Given this list of marker genes H2-Q6, Eif5, N4bp2l2, Fosb, Icosl, Pnkd, Ciao2a, Fchsd2, Ccl22, Bmt2, Rassf4, Slc4a8, Tpm1, Creg1, Cd44, Gramd1b, Colgalt1, Hspa1b, Slc44a1, Klf7 (NCBI Gene Id 93691), Tcf3, Sik2, Slc25a29, Pkd1, Mob3a, Tspan3, Uqcr10, Swap70, Atp2b1 (ATPase, Ca++ transporting, plasma membrane 1), Znrf2, Zc3h12c, Arhgap22, Mknk2, Rab32, Sox4, Hspa1a, Kctd12, Pbxip1, Ankrd35, Mrpl33, Tspan33, H1f2, Tuba1c, Mylip, Nrp2, Topbp1, Tcf7l2, Septin9, Mt2, Gpx1 (NCBI Gene Id 14775), Tmem158, Anxa3, Gpx4 (glutathione peroxidase 4), Ppp4r2, Ebi3, Wdr91, Pnisr, Ankrd33b (ankyrin repeat domain 33B), Huwe1 (NCBI Gene Id 97602), Rgs3, Clu, Calr, Rubcn, Mt1, Slco5a1, Synpo2, Dennd4a, Jun, Arhgap31, Srrm2, Ttc14, Ftl1, Tnfrsf1b, Insr, Mark3, Nabp1, Sec11c, Ucp2, Sema4a, Vhl, Tnfaip2, Chka, Kcnq1ot1, Sdhaf1, Tnrc6b, Plxnd1, Dusp1, Sema6d, Malt1, Glipr1, Prex1, Zfp445, Lmo4, here is a description of the gene set: Genes negatively differentially expressed in cell type: MigDC (migratory dendritic cell) upon treatment with cytokine: IFN-α1 in mouse lymph nodes in vivo. Cytokines mediate cell-cell communication in the immune system and represent important therapeutic targets. A myriad of studies have highlighted their central role in immune function, yet we lack a global view of the cellular responses of each immune cell type to each cytokine. To address this gap, the authors created the Immune Dictionary, a compendium of single-cell transcriptomic profiles of more than 17 immune cell types in response to each of 86 cytokines (>1,400 cytokine-cell type combinations) in mouse lymph nodes in vivo. A cytokine-centric view of the dictionary revealed that most cytokines induce highly cell-type-specific responses. For example, the inflammatory cytokine interleukin-1β induces distinct gene programmes in almost every cell type. A cell-type-centric view of the dictionary identified more than 66 cytokine-driven cellular polarization states across immune cell types, including previously uncharacterized states such as an interleukin-18-induced polyfunctional natural killer cell state. species: Mus musculus Mouse Gene Set: CUI_MIGDC_IFNA1_RESPONSE_DN from publication Cui A, Huang T, Li S, Ma A, Pérez JL, Sander C, Keskin DB, Wu CJ, Fraenkel E, Hacohen N (PMID 38057668)